The following is a description of a gene set: studied in species Mus musculus Catalysis of the reaction: n 3'-phosphoadenylyl sulfate + dermatan = n adenosine 3',5'-bisphosphate + dermatan 4'-sulfate + n H+. Mouse Gene Set: GOMF_DERMATAN_4_SULFOTRANSFERASE_ACTIVITY, and this is the list of marker genes: Chst9, Chst11, Chst8, Chst14, Chst13